Given this list of marker genes NOL3, MYOG, FBXO32, CASQ1, DAG1, PRKAG3, TRIM63, SCN5A, AGT, HDAC4, ACTN3, SELENON, here is a description of the gene set: species: Homo sapiens Human Gene Set: GOBP_RESPONSE_TO_STIMULUS_INVOLVED_IN_REGULATION_OF_MUSCLE_ADAPTATION Any process that results in a change in state or activity of a cell or an organism (in terms of movement, secretion, enzyme production, gene expression, etc.) as a result of a stimulus. This occurs as part of the regulation of muscle adaptation.